The following is a description of a gene set: species: Mus musculus Mouse Gene Set: chr14A2, and this is the list of marker genes: Gm19290, Rarb, Thrb, Gm33022, Gm18275, Rpl31-ps3, Gm22499, Pou5f1-rs6, B230110C06Rik, Gm9637, Tpi-rs9, Gm5630, 4921522A10Rik, Oxsm, Gm8582 (predicted gene 8582), Gm31804, Gm10403, Gm15916, 5430414B19Rik, Rpl15, Gm4939, Nr1d2, Lrrc3b, Gm6781, 1700062C10Rik, Gm7089, Gm6773, Ngly1, Gm8584, Gm31517, Ube2e1, Gm18078, Gm7084, Gm8514, Top2b, Gm6122, Ube2e2, Gm31577, Gm8517, Gm22350, Nkiras1, Gm18142